The following is a description of a gene set: part of: Gastrulation The endoderm in mammalian embryos originates from two different populations of cells: the visceral endoderm, which is present before gastrulation as the hypoblast underlying the epiblast, and the definitive endoderm, which is derived from epiblast cells ingressing through the anterior-most region of the primitive streak. After ingression, the cells of the definitive endoderm then intercalate with the cells of the visceral endoderm to form the embryonic endoderm that will give rise to the gut and visceral organs associated with the gut such as the pancreas and liver. In the discoid human gastrula (differs from the rodent gastrula which acquires a cup shape), the endoderm initially is organized in a flat epithelial sheet that later rolls into a tube to form the gut. Due to ethical considerations, research on gastrulation is undertaken primarily in non-human primate species (for example Bergmann et al. 2022) and stem cells, which have provided insight into germ layer formation in human embryos.<br>The definitive endoderm originates in the anterior region of the primitive streak where there are high levels of NODAL signaling (inferred from mouse embryos in Vincent et al. 2003) and lower levels of BMP signaling (inferred from mouse embryos in Bachiller et al. 2000) and Wnt signaling (inferred from mouse embryos in Mukhopadhyay et al. 2001). In mouse, Eomesodermin (EOMES), whose expression is activated by NODAL signaling via SMAD2 and SMAD3 in the primitive streak, is required for formation of both mesoderm and endoderm. Experiments in human embryonic stem cells and mouse embryos indicate that EOMES is a core element of a gene regulatory network that specifies definitive endoderm by activating expression of transcription factors such as FOXA2 and SOX17 which then activate sets of endodermally expressed genes. As endoderm progenitors enter the primitive streak they redistribute E-cadherin (CDH1) on their surface, which may play a role in sorting the cells into an epithelial layer (inferred from mouse homologs in Viotti et al. 2014). Unlike mesoderm, endoderm progenitors do not undergo a complete epithelial to mesenchymal transition (EMT) (inferred from mouse embryos and stem cells in Scheibner et al. 2021). They do not switch cadherin expression from E-cadherin (CDH1) to N-cadherin (CDH2) and do not require the EMT transcription factor SNAI1 (inferred from mouse homologs in Scheibner et al. 2021). The endodermal transcription factor FOXA2 may repress EMT activity (inferred from the mouse homolog in Scheibner et al. 2021).<br>Though no single marker gene is expressed exclusively in definitive endoderm, the definitive endoderm is characterized by the expression of a combination of genes, including FOXA2, SOX17, GATA4, GATA6, CXCR4, GSC, and E-cadherin (CDH1). CDH1, a general marker of epithelial cells, and the chemokine receptor CXCR4 are often used together as surface markers of definitive endoderm (inferred from mouse homologs in Yasunaga et al. 2005). Reactome Pathway: Formation of definitive endoderm species: Homo sapiens, and this is the list of marker genes: SMAD3, EOMES, CTNNB1, TCF7L2, FOXA2, SMAD2, GATA6-AS1, GATA6, SOX17, CXCR4, GSC, SMAD4, TBXT, MIXL1, CDH1, GATA4, GSC-DT, DEANR1